Given this list of marker genes BCL9L, RPS10, MAFG-AS1, TBC1D16, NUDT3, WDR18, REX1BD, ORAI2, MRC2, HOXC9, MAFG, ST3GAL2, TONSL, HSD17B14, CPLX2, APBB3, OPLAH, FBXO44 (F-box protein 44), RNF43, FAM98C, MPLKIP (NCBI Gene Id 136647), C3orf18, NAGK, TRIM56 (NCBI Gene Id 81844), PKDCC, SLC39A1, MEGF6, FKRP (NCBI Gene Id 79147), ZBTB7A, FKBP2, ZNF428, SNX12, CHTF8, WBP1, NOTCH3, NDUFA3, ZNHIT2, NEAT1, LMF1, HDAC11, APC2, CEBPA, STUB1, SPDEF, NDUFA1, SLC38A10, TSR2, MATCAP1, COL27A1, FAM201A, DND1, ELK1, RPL36, HNRNPA0, FOSL2, OGFR, TSC22D4, DGKQ, BAX, LSR, COL4A4, MXD3, PIGQ, FAM171A2, REXO1, SPATA2L, OVCA2, NAT8L, SPC24, MZF1, RASSF10, BAHD1, TRIP6, ENGASE, SLC35E2B, ERF, ZFYVE27, SLC7A7, CMTM8, PHETA1, ZNF696, KIF12 (NCBI Gene Id 113220), PHLDB3, FAM20C, SNORD104, MAFK, IFI27L2, ELFN2, C11orf68, GPANK1, RPL39, KLHDC8B, PCK2, CACFD1, FBXW4, MRM1, GIGYF1, SDSL (serine dehydratase like), IBA57, ZNF687, MESP1, HMOX1 (heme oxygenase 1), ZNF446, RBP5 (retinol binding protein 5), LINC00205, RAD51D, ARHGAP33, OPN3, TYSND1, SP9, MSC, SLC16A13, SLC25A29, RPL8, SMIM29, PVRIG, CHPF2, CEBPD, here is a description of the gene set: from publication Blanco-Melo D, Nilsson-Payant BE, Liu WC, Uhl S, Hoagland D, Møller R, Jordan TX, Oishi K, Panis M, Sachs D, Wang TT, Schwartz RE, Lim JK, Albrecht RA, tenOever BR (PMID 32416070) Analysis of the transcriptional response to SARS-CoV-2 compared with other respiratory viruses, including MERS-CoV, SARS-CoV-1 (SARS), human parainfluenza virus 3 (HPIV3), respiratory syncytial virus (RSV), and IAV. Human Gene Set: BLANCO_MELO_INFLUENZA_A_INFECTION_A594_CELLS_DN Genes down-regulated in IAV (A549 cells, MOI: 5, 9hpi) species: Homo sapiens